Given this list of marker genes INTS4, UBXN2A, CSE1L, CHD2, CPEB2, CEP170B, TMEM176A, PML, OGDH (NCBI Gene Id 4967), EIF2B3 (NCBI Gene Id 8891), NCOA1, SLC38A2, PHKA1, TLNRD1, VPS37B, ITGAE, MAP3K9, IL21R, RGS2, CEP83, LINC00511, DUSP5, MFAP1, MAPRE2, LRRC56, MAPK11, GNA13, PACSIN1, FOXA1, EPB41, C15orf39, CYP51A1, SLPI, EHD4, SERTAD1, LITAF, SLC41A1, MEX3B, ZFP36L2, DYRK3, APPBP2, BRI3, HSPA2, SATB1, RASA3, PLCL2, TTYH2, RIPK2, ASAP1, ABCA1, HIC1, CUL2, LNX2, DIPK1A (divergent protein kinase domain 1A), SLC41A2, DNM3, QPRT, DAD1, TMEM176B, HVCN1, HMGN5, TECPR2, LRRC8C, GLIPR2, GAS6, DGKD, SRGN, CMIP, C3orf70, ASPH, RETREG1, TBX21, VAMP4, CLK3, ATP6V1E1 (ATPase H+ transporting V1 subunit E1), ASNS, COL27A1, MTSS1, NDEL1, METRNL, CCL22, RSRC2, KMT2D, GHITM, COQ10B, FLNA, TMEM237, ABCA4, ZBTB10, ILDR1, JDP2, DIPK2A, ARIH1, DUSP3, ARID3B, FCGRT, SIRT1, ARHGAP29, DNAJB2, IFNLR1, YES1, DLG5, CASS4, NPRL3, EPN2, VTI1A, ING3, CTSV, ANKRD44, CCDC91, F2RL1, PLEKHO1, TSPAN33, VSIG10, IL2RB, IL6R, ERP44, ARHGEF3, STK17B, SMPDL3A, STAC2, PLEK, BTNL2, KCNK6, RFTN1, ARID5A, IDH1, MFN1, SH3PXD2A, PUM2, SHB, PLS1, TMPRSS13, PDLIM1, GUCD1, PAXBP1, TBC1D14, RASSF6, UBE2G1, ANXA2, UBE2K, CACUL1, AFF4 (NCBI Gene Id 27125), SYT11, TGIF2, CKAP4, C19orf53, PKP4, TEX9, AIDA, INTS6L, DYNC1H1, STX11, DUSP8, SLC5A3, SORBS1, MYPN, SKIL, PPP2R2A, SH3BP5, LIN54, TM4SF5, SCPEP1, SLC66A2, KCTD14, ENPP1 (ectonucleotide pyrophosphatase/phosphodiesterase 1), MYO1G, KRAS, DMPK, IGF2BP3, EMP3, PRSS16, NECTIN1, RASGRP4, RYR1, PPM1G, GLA (galactosidase alpha), TUFT1, PLEKHO2, DMWD, CPM, MXI1, PPP1R2P1, MSH6, CHST7, ERLIN1, PAX4, AGO2, TRIB1, PGAP1, ITGB7, POLE4, GRAMD1A, CDC25B, CDKN2D, HEXIM1, SBK1 (NCBI Gene Id 388228), ZNF703, FNIP1, RAP1B, here is a description of the gene set: Triplicates preparations of RNA from day 10 DC's. Experiment is described in Wong et al 2003 Nat. Immunol. from publication Wong AW, Brickey WJ, Taxman DJ, van Deventer HW, Reed W, Gao JX, Zheng P, Liu Y, Li P, Blum JS, McKinnon KP, Ting JP (PMID 12910265) Genes down-regulated in dendritic cells: wildtype versus CIITA knockout. Human Gene Set: GSE557_WT_VS_CIITA_KO_DC_DN species: Homo sapiens